The following is a description of a gene set: studied in species Homo sapiens from publication Busslinger GA, Weusten BLA, Bogte A, Begthel H, Brosens LAA, Clevers H (PMID 33691112) Human Gene Set: BUSSLINGER_GASTRIC_G_CELLS, and this is the list of marker genes: MAN1A1, C12orf75, QPCT, RAB26, SUCNR1, PCSK1 (proprotein convertase subtilisin/kexin type 1), ARX, HAP1, DST, SLC40A1, PRKACB, PDK4, ACVR1C, CHGB, CMIP, PCSK1N, SELENOW, ANK3, DEPP1, SCG3, PBX3, CXXC4, BTG2, PDLIM5, VAMP2, FKBP2, RFX6, NKX2-2, MEIS2, MAST4, ABCA5, LRP4, DSP, SCGN, FXYD3, MS4A8, CES1, SAMD5, TM4SF4, CAMK2N1, SORL1, NEUROD1, PAX6, TFF3, GAST, CLTRN, DDC, CD36, PAM, KIF1A, NAV1, CPE, MLXIPL, FEV, ERO1B, SCGB2A1, DIRAS3, DTNA, KCTD12, SHISAL2B, ISL1, BPTF, MAP1B, SYT7, ABCB10, SSTR2, RAB3B, INSM1, SCG5, MARCKS, MDK, HLA-A, SLC7A1, PLXNA2, PDE8B (phosphodiesterase 8B), KLB, TM4SF5, CACNA1A, PDK3, PCSK2, TMEM176B, NOL4, SEC11C, GNAI2, PEMT, EGR1, SPINT2, PFN2 (profilin 2), PCLO, CADPS, TPD52, SCG2, SSR4, HIGD1A, ARFGEF3, IDH1, SORBS2, TIMP1